The following is a description of a gene set: part of: Diseases of DNA repair Defects in mammalian DNA mismatch repair (MMR) genes (MLH1, PMS2, MSH2, and MSH6) are characterized by microsatellite instability and reduced fidelity during replication and repair steps. The MMR proteins interact with each other to execute steps within the mismatch repair pathway. Defective variants of these proteins are associated with nonpolyposis colorectal cancer. The MutS proteins are thought to directly contact double-stranded DNA, scanning along the genomic DNA for mismatches analogous to a "sliding clamp" until they encounter a base pair containing a mismatch. The MutS proteins interact with multiple proteins including other MLH and MutL, the later have significant amino acid identify and structural similarity to the MLH proteins, as well as RPA, EXO1, RFC, possibly HMGB1, and other less well-characterized proteins.<br><br>With respect to the mutator function, the MSH2/MutSaplha heterodimer is thought primarily to repair single-base substitutions and 1 bp insertiondeletion mutations, while MSH2/MutSbeta is thought primarily to repair 1-4 bp insertiondeletion mutations. The MLH and MutL heterodimer proteins interact with heterodimers of MutS proteins to help catalyze different functions. MLH1:MutLalpha is the primary complex that interacts with both MutS alpha and beta complex in mechanisms thought to be relevant to cancer prevention. Recent studies suggest that MLH1:MLH3 may also contributes to some of these processes as well, but in all mechanisms tested to a lesser degree than MLH1:PMS2.<br><br>Heterozygous mutations in the MLH1 gene result in hereditary nonpolyposis colorectal cancer-2.<br><br>Variants of the MSH2 gene are associated with hereditary nonpolyposis colorectal cancer. Alteration of MSH2 is also involved in Muir-Torre syndrome and mismatch repair cancer syndrome.<br><br>Defects in the MSH3 gene are a cause of susceptibility to endometrial cancer.<br><br>Defects in the MSH6 gene are less common than MLH1 and MSH2 defects. They have been mostly observed in atypical HNPCC families and are characterized by a weaker family history of tumor development, higher age at disease onset, and low degrees of microsatellite instability (MSI).<br><br>Mutations in the PMS2 gene are associated with hereditary nonpolyposis colorectal cancer, Turcot syndrome, and are a cause of supratentorial primitive neuroectodermal tumors. Heterozygous truncating mutations in PMS2 play a role in a small subset of hereditary nonpolyposis colorectal carcinoma (Lynch syndrome, HNPCC-like) families. PMS2 mutations lead to microsatellite instability with carriers showing a microsatellite instability high phenotype and loss of PMS2 protein expression in all tumors. Reactome Pathway: Diseases of Mismatch Repair (MMR) studied in species Homo sapiens, and this is the list of marker genes: MSH6, MSH2, MSH3, MLH1, PMS2